The following is a description of a gene set: electronically inferred by orthology from the curated human pathway species: Mus musculus part of: Metabolism of lipids Reactome Pathway: Lipid particle organization This event has been computationally inferred from an event that has been demonstrated in another species.<p>The inference is based on the homology mapping from PANTHER. Briefly, reactions for which all involved PhysicalEntities (in input, output and catalyst) have a mapped orthologue/paralogue (for complexes at least 75% of components must have a mapping) are inferred to the other species., and this is the list of marker genes: Fitm1, Cidea, Cidec, Hilpda, Hsd17b13